Given this list of marker genes PRPS1, FANCC, AMD1, BRMS1L, NR4A3, PPP1R10, LURAP1L, DNMT1, TOPBP1, BNC2, TAOK2, CSDE1, TRMT2A, H2BC17, SDHAF2, PCNA, CA10, SYNGR4, EED, ALDH6A1, YTHDC1 (YTH N6-methyladenosine RNA binding protein C1), HMGXB4, E2F7, PCSK1, PTBP2, ADNP, MYC, MCM3, H2BC12, KHSRP, ECEL1, RMI2, CHD4, LZTS2, AK2, NLGN3 (NCBI Gene Id 54413), PRKDC, WEE1, MCM2, RFC5, MCM4, PIK3R3 (NCBI Gene Id 8503), RNF121, AP1S1, HOXC4, NASP, NECTIN1, ARID4A, TMEM143, HNRNPD, ELAVL4, SMC4, SFMBT1, MARCKSL1, E2F1, GATA6, CHD6, CASP2, RARB, USP2, GRIA4, NOLC1, E2F3, H2AC12, DCHS1, H2AC17, RANBP1, H2AX, here is a description of the gene set: Genes having at least one occurrence of the motif TWSGCGCGAAAAYKR in the regions spanning 4 kb centered on their transcription starting sites. This matches the transcription factor binding site V$E2F_01 (v7.4 TRANSFAC). species: Homo sapiens Human Gene Set: E2F_01